Given this list of marker genes NAA50, NAA10, NAA15, NAA11, NAA16, here is a description of the gene set: species: Homo sapiens Human Gene Set: GOCC_NATA_COMPLEX A conserved complex that catalyzes the transfer of an acetyl group to an N-terminal Ser, Ala, Gly, or Thr residue of a protein acceptor molecule. In Saccharomyces the complex includes Nat1p and Ard1p, and may contain additional proteins.